The following is a description of a gene set: species: Homo sapiens Influenza genomic RNA (vRNA), synthesized in the nucleus of the infected host cell, is packaged into ribonucleoprotein (RNP) complexes containing viral polymerase proteins and NP (nucleocapsid). NP trimers bind the sugar phosphate backbone of the vRNA. As influenza viral RNP complexes are too large for passive diffusion out of the nucleus, utilization of the cellular nuclear export machinery is achieved by viral adaptor proteins. Matrix protein (M1) is critical for export of the complex from the nucleus, mediating the interaction of the RNP complex with the viral NEP/NS2 protein, which in turn interacts with host cell CRM1/exportin-1 nuclear export protein. part of: Influenza Infection Reactome Pathway: Export of Viral Ribonucleoproteins from Nucleus, and this is the list of marker genes: PA, NUP85, SEH1L, POM121C, NUP42, NUP155, NUP93, NUP210, PB1, POM121, RAN, SEC13, NP, NUP43, NUP35, NUP98, NUP50, NUP205, NUP54, NUP62, NUP58, NUP160, AAAS, NUP37, TPR, NUP88, M, NUP107, XPO1, PB2, NUP153 (NCBI Gene Id 9972), NDC1 (NDC1 transmembrane nucleoporin), RAE1, RANBP2, NUP214, NS, NUP188, NUP133, HSPA1A